The following is a description of a gene set: Mouse Gene Set: GOBP_REGULATION_OF_PROTEIN_COMPLEX_STABILITY Any process that affects the structure and integrity of a protein complex by altering the likelihood of its assembly or disassembly. species: Mus musculus, and this is the list of marker genes: Washc4, Igtp, Trappc11, Hspa8, Snf8, Tbx3, Irgm1, Trex1 (three prime repair exonuclease 1), Luzp1, Pcm1, Ecsit, Cstpp1, Sqstm1, Scoc, Tapbp, Irgm2, Ncln